Given this list of marker genes XRCC2, HMGB1, XRCC3, WRN, RAD51D, MEN1, RAD51B, FANCM, MSH2, BLM, HMGB2, MSH6, YY1, HMGB3, RAD51C, ABL1, GEN1, here is a description of the gene set: Human Gene Set: GOMF_FOUR_WAY_JUNCTION_DNA_BINDING Binding to a DNA segment containing four-way junctions, also known as Holliday junctions, a structure where two DNA double strands are held together by reciprocal exchange of two of the four strands, one strand each from the two original helices. studied in species Homo sapiens